The following is a description of a gene set: Genes down-regulated in comparison of naive CD8 T cells versus unstimulated neutrophils. Human Gene Set: GSE22886_NAIVE_CD8_TCELL_VS_NEUTROPHIL_DN from publication Abbas AR, Baldwin D, Ma Y, Ouyang W, Gurney A, Martin F, Fong S, van Lookeren Campagne M, Godowski P, Williams PM, Chan AC, Clark HF (PMID 15789058) Immune cell-specific expression is one indication of the importance of a gene's role in the immune response. In order to identify such patterns, we set out to broadly profile gene expression in a variety of immune cells. studied in species Homo sapiens, and this is the list of marker genes: SASH1, PAX7, PRDM9, MMP19, NAMPT, NRN1, MAP2, LY96, TGFA, C5AR1, IL1RL1, SPMAP2, SPRR2B, LALBA, AQP9, SERPINA1, VDR, RAB36, GNG10, TTC39A, LAMB2, SAG, DPEP3, LINC00652, TUFT1, PTGS1, FAM163A, HTRA1, CD4, CCDC170, ENDOU, COQ8B, CD33, CTSS, ZCCHC24, CEBPD, SLC22A4, RAB20, SLC6A5, DHRS9, SRPK3, S100A12, KCNQ1DN, TUB, GLUL, CFTR, NFASC, DDR1-DT, ZNF460, TGFB3, C5AR2, KCNJ2, FTH1P5, TREML2, NUP214, SLC31A1 (NCBI Gene Id 1317), SLC7A11, CEBPB, HSPB2, CDC42EP4, LAMP5, S100A9, SKAP2, TEX13A, SAT1, LITAF, LST1, DRAM1, CYBB, IL1B, RGS4, CCRL2, SDC2, FAS (Fas cell surface death receptor), CSTA, UPK3A, NCR2, SOCS7, ITGA2, PTGS2, CYB5R4, ALOXE3, GALNT14, ERC2-IT1, DDN, MPPE1, APH1B, PI15, RPGRIP1, HSD11B1, BAMBI, KCTD15, FCGR3B, RUBCNL, FGL2, RGS2, VNN3P, ST20, SRGN, BRCA1 (NCBI Gene Id 672), APBA1, PRKCE, PHC2, CSF2RB, GRIK3, TLR6, TALDO1, TYROBP, S100P, TNFSF10, PDK4, PRDM5, EPHB1, ST8SIA5, RAB5IF, LHX6, BCL2A1, LYN, LHX2, FRAS1, BASP1, FUT9, IL3RA, ANGPTL2, SDCBP, HMGB3P1, LIF, DGKG, ZNF415, CCL8, DYRK3, SERHL2, FPR1, NCOA4, PAMR1, B3GNT3, ITIH5, CCL16, ESR2, ALOX5, VNN2, ANXA13, SLC16A3, TUBA1A, HLA-C, STX3, H4C8, CHEK2, ADGRG3, CLEC7A, TREM1, CHST4, FTH1, ABCB9, ARPC5, NPL, CXCL1, MPZL1, NCF2, ADAM28, CHP2, SOD2, H2AC6, CHRDL1, MYCBP, HSPA6, TOR4A, UNC13B, PDK3, MNDA, ECHDC3, SAMD4B, FOLH1B, STMN2, CAMP, INSR, INSL5, DNAAF1, RNF130, CYP2A7P1 (cytochrome P450 family 2 subfamily A member 7 pseudogene 1), WFDC2 (WAP four-disulfide core domain 2), SCG2, LGI2, DNASE1L3, RAB32, GCA, ZNF185, ADAM30, QPCT, PART1, RORB, PRUNE2, SCUBE3, ACSL1 (NCBI Gene Id 91249), SMAD9, C3orf36, TNFRSF10C